Given this list of marker genes CYTH2, TGIF2, THAP2, H2BC7, FBXW11, KPNB1, SPEG, ZFX, RPL10A, CYP1A1, GRIK3, TRIM39, CNOT10, PANK3, TSSK4, ELAVL3, LMO4, EED (embryonic ectoderm development), DMD, PDZD4, NADK2, KCNA6, TP53, NTRK3, ITPR1 (inositol 1,4,5-trisphosphate receptor type 1), PAK6, PIH1D2, NCAM1, ATF2, KNCN, SLC22A8 (solute carrier family 22 member 8), CHRM1, NRF1, H2AC7, PCBP2, MRTFA, PLAGL2, BCL11A, HMG20B, SENP3, SUPT16H, MNT, EGR1 (NCBI Gene Id 1958), VAMP3, POLG, DYNLL1, PRX, ZNF689, NEUROG2, MORF4L2, PICALM, NKAPD1, CCND1, NR3C1, TTBK2, ANGPTL2, RTN4, DPYSL2, H1-0, H3C4, CREBRF, RUNX3, GARS1, ZFC3H1, POLD4, here is a description of the gene set: Human Gene Set: AHR_01 Genes having at least one occurrence of the motif CCYCNRRSTNGCGTGASA in the regions spanning 4 kb centered on their transcription starting sites. This matches the AHR transcription factor binding site V$AHR_01 (v7.4 TRANSFAC). species: Homo sapiens